The following is a description of a gene set: An immunoglobulin complex that is present in the plasma membrane of B cells and that in its canonical form is composed of two identical immunoglobulin heavy chains and two identical immunoglobulin light chains and a signaling subunit, a heterodimer of the Ig-alpha and Ig-beta proteins. Mouse Gene Set: GOCC_B_CELL_RECEPTOR_COMPLEX studied in species Mus musculus, and this is the list of marker genes: Syk, Ighe, Iglc1 (immunoglobulin lambda constant 1), Cd79b, Cd79a (NCBI Gene Id 12518), Lime1, Ighm, Ighd